The following is a description of a gene set: The chemical reactions and pathways resulting in the breakdown of glycerolipids, any lipid with a glycerol backbone. Mouse Gene Set: GOBP_GLYCEROLIPID_CATABOLIC_PROCESS species: Mus musculus, and this is the list of marker genes: Inpp5f, Plcb1, Abhd16a, Scarb1, Pla2g6, Abhd12b, Apoa5, Abhd5, Gpld1 (glycosylphosphatidylinositol specific phospholipase D1), Lipg, Pla2g7, Plb1, Gdpd3, Pnpla5, Lypla2, Pnpla8, Plcb3, Lipe, Lpl (NCBI Gene Id 16956), Aadac, Prdx6b, Fgf21, Enpp2, Sorl1, Apob, Apoc2l, Gpcpd1, Plin5, Gdpd1, Pla2g4d, Pla2g4a, Mgll, Apoa4, Pla2g4e, Ldlr, Pnliprp2, Apoc3 (apolipoprotein C-III), Apoc2, Lipc, Pla2g10, Plcg1, Pla2g4f (NCBI Gene Id 271844), Pla2g4b, Pik3cg, Abhd12, Apoc1, Cps1, Dgkd, Pnlip, Abhd16b, Abhd6, Daglb, Ces1d (NCBI Gene Id 104158), Smpd4, Prdx6, Ddhd2, Pla2g4c, Pnpla3, Dagla, Faah, Pnpla7, Apoh, Pnpla2, Abhd2, Pla2g5, Gpihbp1, Pla2g15, Pnliprp1, Apoa2, Pnpla1